Given this list of marker genes CASP2, MMP2 (NCBI Gene Id 4313), CASP1 (NCBI Gene Id 834), CASP3 (NCBI Gene Id 836), MYC, FGF2, BCL2, MMP9, NSG1, CASP7, here is a description of the gene set: Human Gene Set: BAKER_HEMATOPOESIS_STAT1_TARGETS Hematopoiesis is the cumulative result of intricately regulated signaling pathways that are mediated by cytokines and their receptors. Proper culmination of these diverse pathways forms the basis for an orderly generation of different cell types. Recent studies conducted over the past 10-15 years have revealed that hematopoietic cytokine receptor signaling is largely mediated by a family of tyrosine kinases termed Janus kinases (JAKs) and their downstream transcription factors termed STATs (signal transducers and activators of transcription). Aberration in these pathways, such as that caused by the recently identified JAK2V617F mutation, is an underlying cause for diseases such as leukemias and other myeloproliferative disorders. This recent discovery, when coupled with the fact that STATs are activated by oncoproteins such as BCR-ABL, underscores the importance of the JAK-STAT pathway in both normal cellular development and disease states. from publication Baker SJ, Rane SG, Reddy EP (PMID 17934481) studied in species Mus musculus STAT1 targets in hematopoetic signaling.